Given this list of marker genes Ttll11, Tpgs1, Cep41, Ttll7, Ttll4, Ttll9, Ttll6, Cfap20 (cilia and flagella associated protein 20), Ttll1, Ttll5, here is a description of the gene set: species: Mus musculus Mouse Gene Set: GOBP_PROTEIN_POLYGLUTAMYLATION The addition of one or more alpha-linked glutamyl units to the gamma carboxyl group of peptidyl-glutamic acid.